Given this list of marker genes LCP2, HLA-E, KLRK1, PIK3R2, HLA-C, KLRC2, PLCG1, GRAP2, PLCG2, NRAS, SHC1 (SHC adaptor protein 1), CD300E (CD300e molecule), CLEC5A (C-type lectin domain containing 5A), B2M, LAT, PIK3CB, CD300LB, KRAS, LCK, NCR2, BTK, KIR3DS1, SIRPB1, TYROBP, SIGLEC14, HLA-B, KIR2DS4, SIGLEC15, VAV2, PIK3R1, RAC1, ENSG00000284217, TREM2, VAV3, SOS1, TREM1, HRAS, GRB2, KIR2DS2, PIK3CA, KIR2DS1, KLRD1, KIR2DS5, FYN, SYK, here is a description of the gene set: studied in species Homo sapiens DAP12 interactions Human Gene Set: REACTOME_DAP12_INTERACTIONS